The following is a description of a gene set: Murine Cytomegalovirus (MCMV) infection leads to early activation of various immune cells, including B and T lymphocytes, before the actual initiation of antigen-specific adaptive immunity. This activation is partly driven by innate cytokines, including type I interferon (IFN), which are induced early after infection. The objective of this study was to address the role of type I IFN in shaping early/innate B and T cell responses to a primary acute viral infection. In order to decipher the specific impact of IFN-I on cell subsets, we performed a genome-wide expression analysis on WT splenic B and CD8 T lymphocytes isolated from C57BL/6 mixed bone marrow chimera mice. This study complements series GSE39555, which focused on early responses of NK cells and of the two subsets of conventional dendritic cells. Genes up-regulated in CD8A dendritic cells: wildtype versus IFNAR1 knockout. Human Gene Set: GSE45365_WT_VS_IFNAR_KO_CD8A_DC_UP studied in species Homo sapiens, and this is the list of marker genes: CZIB, SERP1, ATP5IF1, ATRAID, NME4, CORO1A (coronin 1A), MRPL34, SLC27A3, ZNF835, DESI2, IL16, DDX11 (DEAD/H-box helicase 11), GET1, CEP104, FAXDC2, SHMT2, RAD17, GSTK1, PRELP, SYNC, UBE2D4, RETREG2, SIGLEC6, ASL, TTC22, AHI1, HMGB1, ACADM, CXXC1, GALNT7, COX10, LAMTOR2, ENTREP3, MNT, MPV17, RANGRF, STAC, MRPL42, DNMT1, ABHD10, POLR2G, PEX2, PSTPIP1, LMAN2L, TIMELESS, VAV3, SLC25A5, DGKG, PGAP2, COX11, IRAG2, TSPO, ESYT1, CXCR1, PARVB (parvin beta), FAM13A, MTHFSD, ZNF43, MYCL, MRC1, ZNF154, ACAT1, PEX19, BRD3, RER1, BMX, SLC25A36, TMEM134, TSEN2, MRPL58, TXN2, ZNF816, PECAM1, CEP164, ANAPC5, TMED10, SCNM1, SCRN1, HCP5, EEF1G, HAUS4, TRIAP1, CCDC87, LRRC8D, TARBP1, GLB1, ARHGAP19, TRAPPC9, SLC35A1, LBP, INPP4A, AP1S1, LCT, CLNS1A (chloride nucleotide-sensitive channel 1A), GAA, APP, PCYOX1L, CAPRIN2, MID1IP1, PECR, PDHB, UQCRC1, SNX5, GARRE1, ACAD8, MAGED1, CAT, TMEM223, CHKB, GPRC5D, SEPTIN11, CDIPT, ADD3, CCDC28A, TMSB15A, RPN2, NDUFS3, LBR, ZNF93 (zinc finger protein 93), MTX2, HMOX2, ADTRP, ACTB, RPP38 (NCBI Gene Id 10557), CTBP1, PELI2, S100PBP, PIGT, SPDL1, TDP1, MXI1, GPD1L, LDHB, AMZ2, WAS (NCBI Gene Id 7454), SLC29A3, GDE1, MRPL16, TBL1X, ACAA2, STX6, ECHDC3, TTC19, MAPK14, IFFO1, TESK2, PLBD1, CCDC92, USP13, RHOD, PIAS3, MDH1, TGFBR2, G6PC3, LIPA, FRAT2, CTC1, IDH1, IL11RA, ACVR2B, RCOR3, SYNGR2 (synaptogyrin 2), EIF3E, F2RL1, RMND5A, IL13RA1, BLTP2, NKRF, ATP5MC3, SIRT3, COA1, ZDHHC24, AP2S1, PYCARD, HDDC2, DIS3, RTN1, ANP32A, HOXC11, PIGB, PPP2R5A, RFPL2, PIGF, BCL9, SF3A2, ZNF106, BABAM1, CADM3, MBP, PRKACA, ZNF862, UROS, GSTZ1, RBL2, HCFC1R1, ATIC, SV2A